The following is a description of a gene set: studied in species Homo sapiens Human Gene Set: GOMF_ASPARTIC_TYPE_PEPTIDASE_ACTIVITY Catalysis of the hydrolysis of peptide bonds in a polypeptide chain by a mechanism in which a water molecule bound by the side chains of aspartic residues at the active center acts as a nucleophile., and this is the list of marker genes: PSEN1, PGA3, NRIP2, PRNP, SPPL2B, CRB2, WFDC2, DDI2, SPPL3, GAPDH, PGA4, CTSD (NCBI Gene Id 196214), DDI1, PGC, NAPSA, BACE1, CASP3, BIN1, CTSE, NRIP3, PSEN2 (presenilin 2), REN, BACE2, NLRP7, HM13, ASPRV1, SORL1, PGA5, ASTL (astacin like metalloendopeptidase), NCSTN, PIP, SPPL2A, SPPL2C, CASP7